Given this list of marker genes Xirp2, Vegfc, Ppig, Ikbip, Csmd2, Ephb2 (NCBI Gene Id 13844), Tab3, Tmem64, Palld, Tmem167, Cox11, Tor1aip2 (torsin A interacting protein 2), Pom121, Slc35f3, Kcnn3, Rbpms2, Nemp1, Aph1a, Colgalt2, Tub, Ppfia2, Setd7, Hycc2, Nrbf2, Gnpnat1, Nsd1, Gys1, Rybp, Zhx1, Armc8, Car10, Cxadr, Slc35f1, Cts8, Riok2, Bend4, E2f7, Dpys, Itsn2, Fam184a, Slc10a7, Grm5, Isl1, Fam120c, Spty2d1, Snap25, Abhd17c, Zfp26, Scai, Car7, Samd12, Onecut2, Kcnj3, Itpkc, Ak4, Elmo1 (engulfment and cell motility 1), Nptx2, Ttc9, Pira2, Nabp1, Gcc2, Sec24a, Abl2, Mmp1a, Fam78a, Agfg1, Sp1, Mcmbp, Zfp36l1, Zfp704, Slc22a23, Sim1, Iglon5, Syt1, Gltp, Slu7, Nav2, Galnt3, Stk40, Adamts18, Arhgef40, Kdm3a, Pxmp2, Gria3, Enah (ENAH actin regulator), Socs6 (NCBI Gene Id 77635), Iffo2, Cpne8, Casc3, Luc7l, Naa50, Gab1, 1700066M21Rik, Mosmo, Irs1, Adamts16, Pde3a, Esr1, Kctd11, Smad9, Plk2, Itga4, Itga5, Pgap1, Lonrf1, Sgms1, Cbx5, Nemp2, Tmem25, Tgfbr1, Gpd2, Arhgap21, Rnf38, Ankrd40, St6galnac3, Ccdc88a, Pou2af3, Plpp3, Mmd, Scaf11, Klhdc8a, Selenon, Arhgap32, Mier2, Suz12, 1700025G04Rik, Ubr5, Strn4 (NCBI Gene Id 97387), Nipal4, Cep162, Cacna2d3, Sh3rf1, Ube2w, Dcx, Phactr4 (NCBI Gene Id 97190), Kcnk10, Ech1, Nusap1, Pparg, Dlk1, Pdhx, Mief1, Naa15, Krit1, Ccdc71, Col27a1, Cds1, Ndufs4, Rnf139, Mybpc2, Zfhx3, Rere, Stmn2, Msi2, Fbxo33, Ncapg2, Usp46, Mtcl2, Rps6kb1, Slc39a13, Nus1 (NUS1 dehydrodolichyl diphosphate synthase subunit), Ece2 (endothelin converting enzyme 2), Hoxa5, Lpp, Dpy19l3, Neo1, Tmem240, Ticam1, Bahd1, Msl1, Tmem170, Sec61a1, Ing5, Hic1, Sema6d, Lrat, Car12, Lbh, Nfx1, Abhd17b, Phf6, Tmtc2, Ube2e2, Mnt, Plagl2, Ro60, Phf20, Sh3bgrl2, Erlec1 (endoplasmic reticulum lectin 1), Rgl2 (ral guanine nucleotide dissociation stimulator-like 2), Pdgfra, Stox2, Plxnc1, Paip2, Unc13c, Gigyf2, Arid1b, Cables2, Aff4, Retreg3, Cpeb3, Pde8b, Foxa3, H3f3b, Nrk, Nf1, Magi3, Nsd2, Dnajc3, Csf1, Ngdn, Ankrd6, Usp49 (NCBI Gene Id 224836), Crkl, Vangl1, Hapln1, Ltbp1, Nab1, Med13l, Mtfr1, Rab11fip1, Capza1, Tmem170b, Edn3, Tgds, Trim23, Kcnk2, Med12l, Ppp1r3d, Ywhab, Fbxw7, Lrguk, Phb1, Swsap1, Nrep, Map2k7, Ildr2, Sdha, Epb41l1, Pds5b, Nrp2, Rfxap, Pacc1, Gpr149, Med14 (mediator complex subunit 14), Aff3, Reln, Trim12c, Atxn10, Acvr1c, Mtss2, Stk32a, Ice1, Plekhm3, Ift70a1, Pogz, Hip1, Diras1, Fn3krp, Amer2, Vps4b, Myt1, Wnk1, Fam91a1, Rnf144a, Rsbn1l, Akirin1 (akirin 1), Kmt2a, Eml1, Traf3, Ret, Ppm1e, Ptprt, Zfp664, Adcy2, Rgs8, Acvr2a, Dot1l, Met, Wsb1, Neurod6, Tbc1d22b, Slc39a12, Matn3, Slc6a1, Plppr1, Pard6b, Ccdc92, Rcor3 (NCBI Gene Id 70922), Gabra6, Poglut1, Jag1, Cecr2, Opn4, Bub1b, Rapgef2, Tmem121b, Vangl2 (NCBI Gene Id 93840), Sgcb, Tril, Camta1, B3gnt7, Plekhh1, Kcne4, Ulk1, Erich5, Mdfi, Ino80d, Chd2, Fut9, Kdm7a, Osbpl2, Gcc1, Prr18, Frmpd3, Samd10 (sterile alpha motif domain containing 10), Mapk14, Ugt8a, Cdip1, Peli2, Bag2, Ypel2, 4930564D02Rik, Mtdh (NCBI Gene Id 67154), Xpr1, Kcnd3, Pikfyve, Ubr1, Cipc, Slc5a3, Ttc39a, Slc7a14, Ak2, Snx12, Ngfr, Zfp652, Hlx, Steap3, Sall4, Bcorl1, Klrb1f, Ugcg, Mcf2l, Usp42, Dclre1c, 9130008F23Rik, Rps6ka5, Atp8a1, Limk1, Dtx4, Srek1, Syt4, Mdn1, Dcp2, Usf3, Wbp1l, Eif2s2, Kmt2c, Melk, Sirt1, Pdia5, Ncam1, Tmem178b, Plagl1, Pcdh20, Cnot6, Fbln2, Slc7a11, Sgpp1, Rab36, Mknk2, Fbrsl1, Tbc1d8, Mab21l4, Mapk8ip3, Nxt2, Unc80, Anks1, Arrdc4, Clcn3, Szrd1, Rspo4, Pik3r1, Fryl, Chtf8, Ifih1, Tet1, Btg2, Ptpn9, Eef1ece2, Adgrg6, Pank1, Zfp143, Glipr2, Slc8a1, Syn3 (synapsin III), Ppp1cc, Dcc, Dcun1d4, Rngtt, Dcaf7, Gng12, Cyp39a1, Dnajc13 (DnaJ heat shock protein family (Hsp40) member C13), Arhgap12, Elfn2, Ube2n, Hcn4, Grik3, Abcb9, Sertad2, here is a description of the gene set: species: Mus musculus Mouse Gene Set: MIR_128_3P from publication Chen Y, Wang X (PMID 31504780) Genes predicted to be targets of miRBase v22 microRNA mmu_miR_128_3p in miRDB v6.0 with MirTarget v4 prediction scores > 80 (high confidence targets).